Given this list of marker genes Cntf, Dlx2, Sox9, Casz1, Notch1, Sox8, Dlx1, here is a description of the gene set: Any process that stops, prevents, or reduces the frequency, rate or extent of photoreceptor cell differentiation. An example of this process is found in Drosophila melanogaster. Mouse Gene Set: GOBP_NEGATIVE_REGULATION_OF_PHOTORECEPTOR_CELL_DIFFERENTIATION species: Mus musculus